The following is a description of a gene set: An abnormality of the plantar part of foot, that is of the soles of the feet. Human Gene Set: HP_ABNORMALITY_OF_THE_PLANTAR_SKIN_OF_FOOT studied in species Homo sapiens Abnormality of the plantar skin of foot, and this is the list of marker genes: KRT5, ABCC9, ALOX12B (arachidonate 12-lipoxygenase, 12R type), MBTPS2, PIGL, CYP4F22, SDHC, CFTR, GRHL2, DSG1, WNT10A, RECQL4, SERPINA12, EP300, KLHL24, CTLA4, ABCA12, MAP2K1, AKT1, KRT2, ERCC6, PKP1 (NCBI Gene Id 5317), DSC2, NPM1, USB1, LORICRIN, CTSC, DSP, SUFU, AQP5, SRD5A3 (steroid 5 alpha-reductase 3), CSTA, FIG4, CTC1, MRAS, RHBDF2, WRAP53, KRT16, ZNF469, B4GALT7 (NCBI Gene Id 202179), SDHB, BRAF, AIP, SERPINB7, AAGAB, KDSR, ITGB4, KRT6B, TP63, COL14A1, PLOD1, LAMB3 (NCBI Gene Id 3914), TRPV3, KRT85, FGFR2, GMPPA, RSPO1, PRKD1, PERP, CDSN, KCNJ8, CYP27A1, RTEL1, TAT, KCNN3, COL17A1, AAAS, RIT1, SLCO2A1, SDHD, GPR101, KLLN, PIGQ, PDGFRB, TNFRSF1B, CREBBP, PIGN, GJB6, PTEN, KRT6C (keratin 6C), PTCH1, NECTIN1, LAMC2, STS, ENPP1, LIG4, GJB4, SLURP1, SNAP29, LSS, USF3, PLEC, MTOR, CST6, VPS33B, KRT1, NIPAL4, GJA1, ANAPC1, CD28, KRT74, NHP2, SOX18, HRAS, TRAPPC11, KLK11, DST, KRT6A, SMARCAD1, WRN, KCNH1, FGFR3, SEC23B, C1R, JUP, KRT9, NOP10, MMP1, SASH1, TRPM4, PLAA, KRT14, HNRNPK (NCBI Gene Id 3190), PIK3CA, PPP1R13L, KRT83, PTCH2 (NCBI Gene Id 8643), PNPLA1, GJB3, TINF2, KRAS, COL7A1, TERT, ASXL1, ATP6V1B2, TUFT1, NLRP1, KRT10, GJB2, TERC, FBXO11 (F-box protein 11), MAP2K2, ALOXE3, KANK2, KRT17, PEPD, TGM1, DKC1, LZTR1, CTSB, CAST, POMP, IVNS1ABP (influenza virus NS1A binding protein), ATP2A2, MCOLN1, TYMS, COG6, AP1B1, CARD14, CERS3, LAMA3, FERMT1, ATP6V0A2, MTX2, TBL1XR1, PARN, SDR9C7, CD4, SULT2B1, HPGD